Given this list of marker genes MAP3K1, MAPK9, EGFR, MAPK10, EGF, MAP2K4, HRAS, SOS1, MAPK8, KRAS, GRB2, NRAS, SOS2 (NCBI Gene Id 96829), here is a description of the gene set: Human Gene Set: KEGG_MEDICUS_REFERENCE_EGF_EGFR_RAS_JNK_SIGNALING_PATHWAY studied in species Homo sapiens EGF-EGFR-RAS-JNK signaling pathway. Pathway ID: N00542. Pathway type: Reference. Pathway class: nt06526 MAPK signaling. Pathway Definition from KEGG: EGF -> EGFR -> GRB2 -> SOS -> RAS -> MEKK1 -> MKK4 -> JNK